The following is a description of a gene set: studied in species Homo sapiens Absent hair Human Gene Set: HP_ABSENT_HAIR, and this is the list of marker genes: FGF10, CDH3, GJB2 (NCBI Gene Id 2706), HOXC13, CDSN, EDARADD, KRT85 (keratin 85), PHGDH, POLR1C, PPP2R3C, RNU12, PKP1, SNRPE, ODC1, CYP17A1, NECTIN4, TTC7A, ITGB4, UBE3B, AXIN2, LRP1, TBX3, HR, POLR3A, TCOF1, BRAF (NCBI Gene Id 673), SOX18, KRT74, UROS, TP63, ZMPSTE24, SMARCA2, GJB6, MBTPS2, ANAPC1, PI4KA, KRAS, POLR1B, CWC27, NR5A1, AR, ZBTB20 (zinc finger and BTB domain containing 20), FRAS1, LSS, GJA1, RIPK4, JUP, EDA, LMNA, LTV1, MAP2K2, EPS8L3, RECQL4, DSP, SF3B4, ALX1, TWIST2, GNRH1, POLR1D, APOE, RECQL